Given this list of marker genes Ptk2 (NCBI Gene Id 14083), Gpr21, Mir208a, Vegfa, Dip2b, Map3k13, Rufy3, Eppk1, Rps6kb1 (ribosomal protein S6 kinase, polypeptide 1), Rai1, Syt17, Mir1a-2, Plxna3 (plexin A3), Trp73, Spag9, Mbd5, Zfp418, Dio3, Ifrd1, Omg, Syt3 (synaptotagmin III), Plac8, Cpne6, Cited2, Slit2, Dyrk1a, Ptch1, Rag2, Acacb, Bbs2, Cdkn1b, Nog, Igf1, Ezr, Hey2, Rnf157, Cxadr, Atg16l1, Pex5, Lats2, Slit1, Erbb4, Hnrnpk, Bmpr2, Eif2b2, Spart, Ttc3, Lin7a, Sox15, Hdac6, Tnfrsf12a, Myo5b, Ep300, G6pdx, Zfpm2, Ankrd26, Ngf, Foxc1, Tshr, Serpine1, Tgfbr3, Atp8a2, Mapk11, Cacna2d2, Six4, Lin7b, Ahr (NCBI Gene Id 193333), Mir133a-2 (NCBI Gene Id 723954), Gsk3b, Ulk2, Bcl2, Epha7, Wt1, D130043K22Rik, Bcl2l11, Mfsd2a (NCBI Gene Id 76574), Gjd4, Sema3g, Flvcr1, Wnt2, Hnf1b, Pi16, Srf, Limk1, Sema5a, Ncor1 (NCBI Gene Id 320690), Cdh1, Tbx5, Gata4, Wnt3a, Sin3a, Pin1rt1, Myoz1, Mael, Slc25a4, Flt3, Gja1, Drd2, Lpar3, Slc6a3, Adrb3 (NCBI Gene Id 11556), Kcnk2, Bmp10 (bone morphogenetic protein 10), Sgpl1 (sphingosine phosphate lyase 1), Myh6, Cacng7, Ppard (NCBI Gene Id 69050), Barhl2, Cpne5, Reg1, Cdh4, Spr, Mt3, Hamp, Sod1, Myod1, Bcl11a, Dcx, Wdr36, Plaa, Cdkn1a, Crabp2, App, Rpl4, Afdn, Rab21, Ilk, H19, Ikzf1, Syt1, Grn, Fgfr3, Tbx2 (NCBI Gene Id 21385), Pik3ca, Macf1, Gpat4, Cdkl3, Arhgap4, Tnr, Lep, Tomm70a, Siah1a, Daxx, Ndel1, Ccnb1, Rbm10, Jarid2 (NCBI Gene Id 97879), Wwc2, Ttl, Ncam1, Sirt1, Fgfr2, Il7, Nkx6-1, Sav1, Arhgap32, Capn3, Cav3, Mstn, Serp1, Mycbp2, Men1, Sash3, Spaar, Draxin, Sema4d, Col14a1, Mapt, Pdzd11, Slc23a2, Sh3pxd2b, Creb1 (cAMP responsive element binding protein 1), Fgf20, Sema6c, Dusp6, Stc2, Smad7, Hamp2, Prkdc, Fn1 (NCBI Gene Id 269206), Ghrh, Syt4, Nppc, Actn3, Nrg1, Fxn, Mapk14, Six1, Dll1, Trim46, Pim1, Nkx2-5, Cacna1c, Cdk1, Pafah1b1, Adrb2, Dnm2, Rims1, Foxc2, Ntrk3, Gsk3a, Actr3, Smurf1, Gpam, Stat5b, Gata6, Smo, Mkks, Npy1r, Hsf1, Pls1, Hdac3, Plcb1, Sema3f, Rbp4 (retinol binding protein 4, plasma), Trip10, Alms1, Cxcr4, Mtor, Syt2, Edn1, Hdac2, Tbx20, Ppib, Stat3, Trpv2, Agrn, Gnas, Zmpste24, Slc6a4, Rgma, Agr2, Mag, Ghrhr, Ptprs, Cyfip1, Colq, Stat5a, Ntn1, Shtn1, Fstl4, Dusp10, Rnf6, Rnd2, Foxp1, Pou1f1, Ddx39b, Ghsr, Igf2, Mul1, Fgf2 (NCBI Gene Id 14173), Mir133a-1, Yap1, Vgll4, G6pd2, Fto, Fgf9, Cpne9, Ulk1, Gh, Prkn, Lgmn, Bmpr1a, Cga, Sh3glb1, Golga4, Tgfbr1, Fosl2, Hmga2, Afg3l2, Sptbn4, Map1b, Gamt, Mef2c, Ctdp1, Mtm1, Picalm, Nrp1, Ryk, Megf8, Cdk5, Lats1, Yy1, Dbnl, Musk, Zp3, Sema7a, Suv39h1, Arx, Zfyve27, Mecp2, Fgf8, Dspp, Parp2, Twf2, Apc, Ostn, Mgll, Cttn, Eif4g2, P2rx5, Stk3, Akap6, Foxs1, Itsn2, Unc13a, Sema6d, Insr, Nipbl, Islr2, Pum2, Prox1, Rtn4, Disc1, Cxcl12 (NCBI Gene Id 20315), Wnt5a, Prlh, Rtn4r, Lin7c, Gdi1, Tnks2, Pou3f2, Akt1, Mir675, Wnt3, Agt, Atrn, Stk4, Tll2, Pin1, Wwc1, Trpc5, Gli1, Ist1, Rims2, Tbx1, C3, Cdkl5, Csf1, Sema4f, Ybx3, Adrb1, Nedd4l, Sgip1, Map2, Lrp1, Atxn2, Mapk1, Rasal1 (NCBI Gene Id 19415), Gdf15, Efna5, Rgs2, Fdps, Ccr5, Rgs4, Pak1, Clasp2, Vil1, Dscam, Gdf5, Nr3c1, Sema3a, Azgp1, Adcy10, Dbn1, Apoe, Plxna4, Socs2, Ccnd2, Adnp, Anapc2, Dlg1, Hopx, Igf1r, Drd3, Notch1, Hlx, Htra2, Ccn4, Pou4f2, Bbs4, Pten, Tgfbr2, Bdnf, Fgf13, Celf1, Fgfr1, Cfl1, Zfp640, Ar, Tcf7l2, Olfm1, L1cam, Ghr, Chd7, Ptger4, Ppara, Rbpj, Abl1, here is a description of the gene set: Any process that modulates the frequency, rate or extent of developmental growth. studied in species Mus musculus Mouse Gene Set: GOBP_REGULATION_OF_DEVELOPMENTAL_GROWTH